Given this list of marker genes Rps7, Ivns1abp, Ogt, Cops9, Vps28, Gbp4, Prkcg, Ppia, Per2, Rpl5, Sirt7, Dcun1d3, Ctnnb1 (catenin beta 1), Gtpbp4, Tspo, Tnfaip3, Rpl11, Usp4, Caml, Mtor, Sumf2, U2af2, Mad2l1, Spopl (NCBI Gene Id 99466), Cdkn2a (cyclin dependent kinase inhibitor 2A), Ufl1, Sh3rf2, Hmg20b, Trim44, Park7, Capn3, Adgrb1 (adhesion G protein-coupled receptor B1), P3h1, Gnl3l, Trim21, Prmt3, Hmg20a, Pias3, Atg5, Bag5, Smad7, Cdk5, Peli3, Bag2, Prkce, Svbp, Ube2b, Akt1, Mad2l2, Usp44, Cav1, Limk1, N4bp1, Dnaja1, Gps2, Dtx3l, Abl1, Senp2, Parp10, Ubxn1 (UBX domain protein 1), Sox4, Fscb, Chp1, Rela, Flcn, Arrb1 (arrestin, beta 1), Psen2, Hspa1b, Wnk1, Arrb2, Bex1, Spry2, Rps3, Fyn, Bex2, Dnajb2, Ttc36, Cep63, Nxn, Klhl40, Rpl23, Pinx1, Dysf, Bex4, Isg15, Bex3, Marchf7, Fbxo5, Rasd2, Crtap, Pabpn1l, Minar1, Psen1 (NCBI Gene Id 19164), Gclc, Plaa, Sqstm1, Cry1 (cryptochrome circadian regulator 1), Hdac8, Cep78, here is a description of the gene set: Mouse Gene Set: GOBP_NEGATIVE_REGULATION_OF_POST_TRANSLATIONAL_PROTEIN_MODIFICATION species: Mus musculus Any process that stops, prevents or reduces the frequency, rate or extent of post-translational protein modification.